The following is a description of a gene set: Pathway Definition from KEGG: CD40LG -> CD40 -> (TRAF2+TRAF3) -> NIK -> IKKA -> (NFKB2+RELB) CD40-NFKB signaling pathway. Pathway ID: N00505. Pathway type: Reference. Pathway class: nt06516 TNF signaling. studied in species Homo sapiens Human Gene Set: KEGG_MEDICUS_REFERENCE_CD40_NFKB_SIGNALING_PATHWAY, and this is the list of marker genes: CD40LG, NFKB2, TRAF3, CD40, MAP3K14, RELB, TRAF2, CHUK